The following is a description of a gene set: Human Gene Set: GOBP_IRES_DEPENDENT_VIRAL_TRANSLATIONAL_INITIATION Process by which viral mRNA translation is initiated, where a domain in the 5' untranslated region (UTR) of the viral mRNA called an internal ribosome entry site (IRES) binds the host 43S preinitiation complex, circumventing regular cap-dependent translation initiation. species: Homo sapiens, and this is the list of marker genes: EIF3D, SSB, EIF3A, DENR, EIF2D, PTBP1, CSDE1, PCBP2, EIF3F, MCTS1, EIF3B